Given this list of marker genes Cops5, Klhl15, Dnajc3, Cav1, Parp8, Erp27, Amfr, Ufd1, Nck2 (non-catalytic region of tyrosine kinase adaptor protein 2), Stc2, Erp44, Cul3, Clu, Sdf2l1, Pacrg, Pik3r1, Eif2ak4, Atf6, Chac1, Dab2ip, Tmem129, Ubr4, Derl2, Thbs1, Pdia6, Rhbdd1, Tm7sf3, Manf, Hspb1, Edem2, Dnajb12, Dnajb14, Herpud2, Atf4, Wfs1, Optn, Mfn2, Akt3, Tmed2, Ptpn1, Akirin2, Hspa1a, Rnf126, Qrich1 (glutamine-rich 1), Ufl1, Ern1, Ccnd1, Hsph1, Bok, Vapb, Creb3l4, Gorasp2 (NCBI Gene Id 99405), Pmp22, Atf3, Akt1, Dnajb9, Tmem33, Thbs4, Tram1, Derl3, Abcb10, Ero1a, Yod1, Serp1, Bak1, Hspd1, Dnajc18, Pigbos1, Ube2j2 (ubiquitin-conjugating enzyme E2J 2), Jkamp, Ern2, Fbxo6, Edem3, Hspa4l, Xbp1, Ubxn4, F12, Ppp1r15a, Parp16, Hdac6, Hspb8, Tmbim4, Bfar, Atad3a, Creb3l3, Bhlha15, Bag3, Casp12, Comp, Ermp1, Elp6, Epg5, Creb3l1, Ptpn2, Bax, Umod, Eif2a, Eif2ak3, Os9, Eif2ak2, Agr2, Tbl2, Edem1, Rpap2, Asb11, Cdk5rap3, Stub1, Creb3l2, Serp2, Syvn1, Vcp, Ddit3, Hspa5 (heat shock protein 5), Derl1, Hsf1, Atxn3, Nfe2l2, Ube2w, Upf2, Stt3b, Tmtc4, Herpud1, Creb3, Faf2, Abca7, Daxx, Eif2s1, Nck1, Tmbim6, Ubr5, Dnajc10, Parp6, Lhx1os (NCBI Gene Id 78365), Igtp, Atf6b, Ddrgk1, Ficd, Akt2, Erlec1, Hsp90aa1, Selenos, Crebrf, Ifng, here is a description of the gene set: studied in species Mus musculus Mouse Gene Set: GOBP_RESPONSE_TO_TOPOLOGICALLY_INCORRECT_PROTEIN Any process that results in a change in state or activity of a cell or an organism (in terms of movement, secretion, enzyme production, gene expression, etc.) as a result of a protein that is not folded in its correct three-dimensional structure.